The following is a description of a gene set: species: Homo sapiens Neuromuscular dysphagia Human Gene Set: HP_NEUROMUSCULAR_DYSPHAGIA, and this is the list of marker genes: KLHL41, TPM3, ACTA1, KBTBD13, GALC, COQ2, MYPN, MAPT, NEB, FARS2, TPM2